Given this list of marker genes GPSM2, GNAI1, EPB41, NUMA1, SAPCD2, PPP1R9B, MISP, EPB41L2, PLK1, here is a description of the gene set: Human Gene Set: GOBP_REGULATION_OF_PROTEIN_LOCALIZATION_TO_CELL_CORTEX Any process that modulates the frequency, rate or extent of protein localization to cell cortex. studied in species Homo sapiens